The following is a description of a gene set: studied in species Homo sapiens Human Gene Set: REACTOME_SIGNALING_BY_ERBB2_ECD_MUTANTS Signaling by ERBB2 ECD mutants, and this is the list of marker genes: NRAS, PIK3CA, EGFR, PIK3R1, KRAS, GAB1, SOS1, ERBB2, CDC37, ERBIN, PLCG1, SHC1, EGF, HRAS, HSP90AA1, GRB2